The following is a description of a gene set: The chemical reactions and pathways resulting in the formation of gangliosides that begins with the formation of lactosylceramides, Gal-beta-(1->4)-Glc-beta-(1->1') ceramides, any compound formed by the replacement of the glycosidic C1 hydroxyl group of lactose by a ceramide group. species: Mus musculus Mouse Gene Set: GOBP_GANGLIOSIDE_BIOSYNTHETIC_PROCESS_VIA_LACTOSYLCERAMIDE, and this is the list of marker genes: B4galt6, St3gal1, St3gal3, St3gal2, 6430550D23Rik, B4galt5